Given this list of marker genes AGTR2, REN, AGT, ACE, AGTR1 (NCBI Gene Id 9449), ACE2, CYP27B1 (NCBI Gene Id 5135), CYP2R1, here is a description of the gene set: Non-classical role of vitamin D Human Gene Set: WP_NONCLASSICAL_ROLE_OF_VITAMIN_D species: Homo sapiens